Given this list of marker genes Cfh, Cfb, Cfhr4, Vsig4, C8g, Hc, C8b, Cfd, Cr2, C9, Cfp, Susd4, C3, C8a, here is a description of the gene set: Any process involved in the activation of any of the steps of the alternative pathway of the complement cascade which allows for the direct killing of microbes and the regulation of other immune processes. Mouse Gene Set: GOBP_COMPLEMENT_ACTIVATION_ALTERNATIVE_PATHWAY species: Mus musculus